The following is a description of a gene set: studied in species Homo sapiens Human Gene Set: GOBP_VIRAL_TRANSLATIONAL_FRAMESHIFTING A process which occurs during viral translation, which involves a translational recoding mechanism called programmed ribosomal frameshifting. This causes the ribosome to alter its reading of the mRNA to an a different open reading frame to produce alternate viral proteins., and this is the list of marker genes: ATP7B, SHFL, PEG10, OAZ3, OAZ2, OAZ1